Given this list of marker genes CENATAC, HMGB1P42, DUXAP5, NHERF4, LINC02762, TTC12, TRAPPC4, MTRF1LP1, RBM7, RPS27P19, VPS11, ST13P10, RPS29P19 (ribosomal protein S29 pseudogene 19), ENSG00000287545, RN7SL688P, MIR4301, BCO2, MPZL3, RNU6-1123P, C2CD2L, MIR4491, CADM1, LNC-RHL1, ATF4P4, LINC02550, DSCAML1, NECTIN1-AS1, RN7SL828P, CD3E, ENSG00000287028, MFRP, ENSG00000250493, DLAT, RNA5SP350, ENSG00000286731, GRIK4, ARCN1, LRRC37A13P, ENSG00000297377, C11orf52, HNRNPA1P60, ARHGEF12, ENSG00000300211, BACE1, ENSG00000256195, DIXDC1, HSPB2-C11orf52, TEX12, MIR6716, ENSG00000268472, ANKK1, REXO2, C1QTNF5, TREHP1 (trehalase pseudogene 1), NNMT, MIR6756, BUD13, UPK2, NKAPD1, RPL12P46, HYOU1-AS1, PAFAH1B2, NECTIN1-DT, ENSG00000252992, CD3D, KCTD9P4, HINFP, OAF, BCL9L, ENSG00000259541, TRIM29, POU2AF1, SETP16, HTR3A, TRPC6P5, PRR13P3, LINC02763, LINC02703, CENATAC-DT, NCAM1, RPL37AP8, CFAP68, ENSG00000247416, BACE1-AS, RPL5P30, ARHGAP20, RPS4XP12, TBCEL, SC5D, RNU6-262P, USP2, GNG5P3, FXYD6-AS1, SCN4B, DRD2, SIK2, ENSG00000255428, POU2AF2, MPZL2, NXPE4, FDXACB1, RNU6-893P, ENSG00000176984, TMPRSS5, LINC02698, DDX6 (DEAD-box helicase 6), CBL, LINC02151, MIR34BHG, MCAM, HMBS, DRC12, RPS17P15, BTG4, NCAM1-AS1, HTR3B, APOC3, HSPE1P18, TTC36-AS1, DPAGT1, RNF26, LINC02764, ISG20L2P2, MRPS36P4, TECTA, JAML, ZPR1, ZBTB16, CRYAB, RN7SKP273, USP2-AS1, PLET1, MIR4492, PHLDB1, USP28, SDHD, SIK3, UBE4A, RNU2-60P, RPL23AP64, RPL15P15, PCSK7, ENSG00000287006, BUD13-DT, CD3G (NCBI Gene Id 917), ATP5MG, IL18, TIMM8B, PPP2R1B, KRT8P7, ENSG00000270403, NXPE2P1, LINC02744, TMPRSS4, TMEM25, ELOCP22, VPS11-DT, ALG9-IT1, KMT2A, ENSG00000239153, THY1-AS1, POU2AF3, ZW10, HYOU1, SIDT2, RPS6P16, TMPRSS13, RPS12P21, SMIM35, COLCA1, RNA5SP351, NECTIN1, SLC37A4, LINC02702, LAYN, FXYD6, RNU6-376P, RNU6-1107P, IFT46, RNF214, NXPE2, CLDN25, FXYD6-FXYD2, ENSG00000238724, THY1, CEP164, APOA4, NLRX1, HOATZ, SCN2B, C11orf71, LINC00900, ENSG00000302547, RNU6-44P, IL10RA, MIR34B, FXYD2, APOA5, RNY4P6, MIR34C, PTS, COX7CP3, CADM1-AS1, ABCG4, CXCR5, H2AX, TLCD5, APOA1-AS, FOXR1 (NCBI Gene Id 283150), HSPB2, APOA1, TAGLN, TTC36, RNU7-187P, TTC12-DT, PIH1D2, POU2F3, NXPE1, TBCEL-TECTA, RNU6-1157P, ALG9, RPL23AP62, PPIHP1, TREH, RPS25 (NCBI Gene Id 6230), here is a description of the gene set: Human Gene Set: chr11q23 studied in species Homo sapiens